The following is a description of a gene set: studied in species Mus musculus Mouse Gene Set: GOBP_GLIAL_CELL_ACTIVATION A change in morphology and behavior of a glial cell resulting from exposure to a cytokine, chemokine, cellular ligand, or soluble factor., and this is the list of marker genes: Ldlr, Ifngr2, Mir7116, Tlr4, C5ar1, Csf1r, Zeb2, Nampt, Atm, Ttbk1, Tafa3, Hspa4, Tlr6, Cntf, Tyrobp, Nr1d1, Tlr3, Calhm2, Tlr1, Syt11, Il1b, Tlr2, Adora2a, Stap1, Grn (NCBI Gene Id 14824), Agt, Tlr9, Trpv1, Il13, Tnf, Ctsc, Jak2, Lrrk2, Slc9a6, Ifng, App, Pparg, Ifngr1, Cx3cr1, Sphk1, C1qa (NCBI Gene Id 12259), Lrp1, Casp1, Il33, Cx3cl1, Smo, Mmp8, Psen1, Egfr, Itgam, Naglu, Jun, Kcnj8, Il4, Trem2, Clu, Cst7, Snca, Kcnn4, Ager, Aif1